Given this list of marker genes Gjb1, Gja1, Gjb5, Adam7, Ptpn6, Gjb2, here is a description of the gene set: Mouse Gene Set: GOBP_EPIDIDYMIS_DEVELOPMENT The process whose specific outcome is the progression of an epididymis over time, from its formation to the mature structure. studied in species Mus musculus